Given this list of marker genes Tsr1, Bysl, Imp3, Wdr3, Nudt16l1 (NCBI Gene Id 77104), Nop56, Heatr1, Gar1, Nudt7, Nop10, Sde2, Utp25, Rrp9, Prkdc, Nudt5 (NCBI Gene Id 53893), Dkc1, Isg20, Xrcc5, Nudt1, Nop14, Dhx37, Utp6, Nolc1, Nudt16, Nudt16l2, Snu13 (NCBI Gene Id 20826), Nufip1, Nop58, Ddx21, Tbl3, Nhp2, Nudt4, Bms1, Imp4, here is a description of the gene set: species: Mus musculus Mouse Gene Set: GOMF_SNORNA_BINDING Binding to a small nucleolar RNA.